Given this list of marker genes SMAD4, TERT, CPT2, FGG, BRCC3, DNMT3A, SDHB, EPOR, PDGFB, COL4A1, CST3 (NCBI Gene Id 1471), ZFX, ESAM, BAP1, LMOD2, ABCC6 (ATP binding cassette subfamily C member 6), F13A1, PROS1, KIF1B, FGA (fibrinogen alpha chain), SH2B3, KRIT1, CFH, NF2, FH, SMO, FGB (fibrinogen beta chain), FLNA, CFI, SLC25A11, FCGR2C, MAX, EPAS1, SMARCE1, MDH2, SNORD118, RET, IKBKG, NF1, ACTA1, DLST, CD46, PIK3CA, GDF2, ENG, NOTCH3, CCM2, EXT2, PDCD10, GALE, AKT1 (NCBI Gene Id 207), SMARCB1, NDE1, SDHAF2, USP18, FN1, F13B, ADA2, HELLPAR, HADHB, GGCX, SDHD, TRAF7, SUFU, SDHC, SDHA, STAT2, APP, VHL, JAK2, TMEM127, ACVRL1, here is a description of the gene set: Hemorrhage into the parenchyma of the brain. Human Gene Set: HP_CEREBRAL_HEMORRHAGE Cerebral hemorrhage studied in species Homo sapiens